The following is a description of a gene set: Human Gene Set: MIR597_5P Genes predicted to be targets of miRBase v22 microRNA hsa-miR-597-5p in miRDB v6.0 with MirTarget v4 prediction scores > 80 (high confidence targets). from publication Chen Y, Wang X (PMID 31504780) studied in species Homo sapiens, and this is the list of marker genes: LCK, GPD2, DDX6, ZMYM2, ARHGAP6, XPO7, ACVR2B, CCDC178, PPME1, RWDD2A, MYSM1, PACS1, SLITRK3, HEG1, ARHGAP42, OPA3, BCCIP, SHB, CARTPT, HYCC2, FGFR1OP2, DCLK1, BCL11B, EPB41L5, NLRC5, KIAA0040, ATP1A4, NCAM1 (NCBI Gene Id 4684), FAM111B, ADGRG7, DNAJB6, SCN2A, GPR158, NRK, JAK1, ATXN7, OBSL1, UBE2A, SUSD5, MAPK9, TMEM87A, SNW1, CCDC149, PPP2R2D, TRIM32, FOXF1, LARP4, C1QTNF3, PWWP2A, G3BP2, LIFR, CDK14, SGK1, ABCA1, PRLR, TTC8 (tetratricopeptide repeat domain 8), ZNF25, EIF4E3, PRG4, TLX1, TEAD1, UGT2A3, SLC24A4, DCAF12, BRIP1, ACER2, GABRG1, SRSF3, MOAP1, BOD1L1, FUT8, GJB7, NCBP3, FIGN, AJUBA, ZC3H12C, PRKX, PPP1R27 (protein phosphatase 1 regulatory subunit 27)